The following is a description of a gene set: studied in species Homo sapiens from publication Busslinger GA, Weusten BLA, Bogte A, Begthel H, Brosens LAA, Clevers H (PMID 33691112) Human Gene Set: BUSSLINGER_DUODENAL_BCHE_CELLS, and this is the list of marker genes: CPA2, GUCA2B, FAM13A, GMNN, MT1G, HEPACAM2, KRT20, LYZ, MT1X, PROX1, RBPJ, ID1, CD24, MT1F (NCBI Gene Id 4494), CFTR, TSPAN8, GSN, CTSE, FKBP1A, SPIB, CST3, GUCA2A, LGALS4, RBM47, BEST4, S100A6, TMSB10, KRT72, CA7, CDH17, MT2A, NOTCH2NLA, AKR1C3, TMEM219, PLAC8, NAPSB, SRI, MT1E, ADGRG4, MT1H, GSTP1, LPCAT4, LGALS3